Given this list of marker genes Mfge8, Jmjd6 (jumonji domain containing 6), Anxa1, Xkr7, Xkr6, Hmgb1 (NCBI Gene Id 15289), Itgb3, Cd300lf (NCBI Gene Id 353028), Xkr8, Tyro3, Spg11, Tyrobp, Fcnb, Adgrb1, Thbs1, Trem2, C2, Abca7, Lrp1, Ccl2, Alox15, Ccr2, C3, Cd36, Mertk, Scarb1, Becn1, Axl, Marco, Pear1, Trex1, Gas6, Rac1, Timd4 (T cell immunoglobulin and mucin domain containing 4), Tgm2, Rara, Itgav, Nr1h3, Megf10, Xkr4, here is a description of the gene set: The recognition and removal of an apoptotic cell by a neighboring cell or by a phagocyte. species: Mus musculus Mouse Gene Set: GOBP_APOPTOTIC_CELL_CLEARANCE